Given this list of marker genes Ido1, Acta2, Pecam1, Npnt, Myh11, here is a description of the gene set: The contractile fiber of smooth muscle cells. Mouse Gene Set: GOCC_SMOOTH_MUSCLE_CONTRACTILE_FIBER studied in species Mus musculus